Given this list of marker genes DDX39B, AURKAIP1, TBC1D22A, CTSA, SGK1 (serum/glucocorticoid regulated kinase 1), NCBP2AS2, ARRB1, OSBPL11, KMT5C, TWF2, CDK4, PTS, RERE, FLCN, CIAO1, NME6, SLC10A2, SMIM14, NAXE, CLASRP, FBXW4, ALDH3A2, FAF1, RAB11FIP5, SEC61B, PTOV1, ADD1, ZNF808, RNF220, TRIM47, HFE, TUBB2A (NCBI Gene Id 92919), PPIB, ECHS1, ISOC1, HHEX, VAMP8, CERK, RBCK1, SDC3, SLC35A1, ARL4C, LMO2, ZFYVE19 (zinc finger FYVE-type containing 19), GUK1, LRP1, SELENOH, RIMOC1, PKIG, NFIC, OGDH (oxoglutarate dehydrogenase), IMP3, ANGEL2, YPEL3, GRN, PNKP, CTSE, GLTP, UQCRC1, CMAS (cytidine monophosphate N-acetylneuraminic acid synthetase), DAP, LMAN2, TALDO1, ABCB1, BCAS3, NBR1, AQR, EXOSC7, ABCD1, SUPT4H1, ELP3, APOBEC1, HES6, ERP29, CTPS2, MXD4, NSMAF, RGS2, CIAO2A, MACIR (macrophage immunometabolism regulator), RPL19, RGL2, PTCD2, STMP1, PRKCSH, UQCC1 (ubiquinol-cytochrome c reductase complex assembly factor 1), CXCR4, C3AR1, GTF2H4, LMF1, PSMB6, RCAN3, TMEM179B, CDCA7L, MS4A6A, TLE5, MKRN1, TAF11, WASHC2A, PAFAH1B3, SRP9, PEX11B, CLN6, REEP5, MRPL4, FOXO3, DIP2B, RREB1 (NCBI Gene Id 6239), ATP5PO, NECAP2, MCEE, CXorf38, COMMD4, DAGLB, ATP5F1C, XRCC1 (X-ray repair cross complementing 1), CSK, IDH1, TMEM126A, SCAMP2, EIF3K, MFSD5, MLF2, MRPL34, SCNM1, PPP1R21, CCNDBP1, ST6GAL1 (NCBI Gene Id 6480), DBNDD2, MAST3, ATP6V0D1, SLC38A10, TEP1, CD99, MAPK3, TSPAN32, INPP5D, ARPC1A, PLCG2, ASNSD1, COMMD6, CUTA, TBC1D24, PTPRO, WIPI2, SMIM20, RASAL3, MAN2B1, ING4, OTULINL, LYL1, RNF5, WAS, NDUFA8, WDR81, COMMD1, PPFIA4, ACOT13, FLI1, TRMT2A, MBD3, LAT2, BLNK, DCAF11, VPS37B (VPS37B subunit of ESCRT-I), COLGALT1, ATP6V0E1, STX2, GNA12, LEPROT, HADHB, PLEKHO1, MRPS25, WIPF1, HSD17B11, TIMM8B (translocase of inner mitochondrial membrane 8 homolog B), MAT2B, RING1, PCBD2 (NCBI Gene Id 84105), RIT1, MRPS11, AKT1, MRPL30, EIF4EBP2, CLTA, CBX4, DBP, STK10, AP1B1, DUS1L, SIRT3, PLXND1, SCMH1, HELB, CDT1, TYMP, NDUFS3, CPT1A, ANAPC11 (NCBI Gene Id 51529), MRPL28, here is a description of the gene set: Human Gene Set: GSE42021_CD24INT_TREG_VS_CD24INT_TCONV_THYMUS_UP Genes up-regulated in CD42 int cells from thymus: T reg versus T conv. We investigated at which stage of maturation commitment to a stable Foxp3-expressing phenotype takes place. We assessed stability of Foxp3 expression in thymic Foxp3+ Treg subsets of different maturity, defined by CD24 expression. Next we compared gene expression profiles of Foxp3+ Treg subsets (+) of different maturity (24lo, 24int, 24hi) and could identify a set of genes that were specifically up or downregulated in Foxp3+ Tregs, but not in Foxp3- conventional T cells, in a maturation-dependent manner. species: Homo sapiens from publication Toker A, Engelbert D, Garg G, Polansky JK, Floess S, Miyao T, Baron U, Düber S, Geffers R, Giehr P, Schallenberg S, Kretschmer K, Olek S, Walter J, Weiss S, Hori S, Hamann A, Huehn J (PMID 23420886)